The following is a description of a gene set: Genes predicted to be targets of miRBase v22 microRNA hsa-miR-4726-5p in miRDB v6.0 with MirTarget v4 prediction scores > 80 (high confidence targets). Human Gene Set: MIR4726_5P from publication Chen Y, Wang X (PMID 31504780) species: Homo sapiens, and this is the list of marker genes: IDH3G, SORD, GRK2, BCL11A, TSPAN11, CDC42SE1, RFT1, CHD8 (chromodomain helicase DNA binding protein 8), DUSP13A, TMEM184B, MEST, SUSD6, HPCAL4, TCP11X2, LCOR, ORAI2, VAMP3, CNNM4, ELMO2, TSPAN7, CTNNA2, IMPDH1, RBM14, PPP4C, ALX4, SLC39A13, ZNF540, RANGAP1, NFYA, SNX27, DBN1, CLDN4, RAB1B, UBFD1, LONRF2, IDS, RAB36, GPR137C, PPP4R2, SEMA5B, ADRA1A, TAFA4, CD209, ATF3, DENND1A, NOS1, HS6ST1, POR, RAB4B, BACH2, HCFC2, TP53I11, TCTA, PTPRU, ZNF592, AFDN, TRPM1, MAPK4, TAPBP, MOB1B, FBXO41, GAS8, SNX17, KHNYN, MYLK2 (myosin light chain kinase 2), FCRLA, ZDHHC3, SLC13A4, EBF4, ZNF710, MTCL2, LYPD3 (LY6/PLAUR domain containing 3), CDIP1, FYCO1, NRF1, TFCP2L1, GOLGA4, KCNMA1, GYS1, AK1, HP1BP3, GOLGA6L6, SLC22A13, RIPOR2, EPN2, BNIP2, NRG4, EPB41L1, HEPACAM, MYO1E, MRAP2, TBX21, AGO1, IQSEC3, LOXL3, ITPRIP, NGFR, CAPRIN2, MAGI1, AAK1